Given this list of marker genes SLIT2, PDGFD, MDK, CORO1B, MIR34A, AIF1, GSTP1, LPAR1, here is a description of the gene set: Any process that modulates the frequency, rate, or extent of smooth muscle cell chemotaxis. Human Gene Set: GOBP_REGULATION_OF_SMOOTH_MUSCLE_CELL_CHEMOTAXIS species: Homo sapiens